Given this list of marker genes TYMS, SLC52A3, FOLH1, MTR, DNMT1, TCN2, SLC52A2, AMN, AHCY, MAT1A, NGLY1, DHFR, SHMT1, FOLR1 (folate receptor alpha), SLC19A1, MTHFR, PNPO, FOLR2, MMUT, CUBN, MTRR, CD320, LMBRD1, AOX1, ALPI, MAT2B, HCFC1, GNMT, MMADHC, SLC46A1, SLC52A1, ALDH1L2, MTHFD1, ABCD4, BHMT, MMAA, RFK, CBLIF, PDXK, ALPL, CBS, TCN1, MMACHC, here is a description of the gene set: species: Homo sapiens Human Gene Set: WP_PATHWAYS_INTO_METHIONINE_AND_FOLATE_CYCLES Pathways into methionine and folate cycles